Given this list of marker genes CDKN2A, RAPGEF6, SOS2, RFXANK, SDCBP, EPO, NOTCH1, GRAP, RABGEF1, GRB2, NRAS (NRAS proto-oncogene, GTPase), SYNGAP1, MAP2K1, DOK3, SPRY4, RASGRF1, PLD1, MRAS, SYDE1, ITPKB, RALGPS2, BRAP, RALA, FGF2, NGF, SHOC2, MMD2, DAB2IP, FGF10, TGFB2, RAPGEFL1 (Rap guanine nucleotide exchange factor like 1), KSR1, IQGAP3, RALGDS, KITLG (NCBI Gene Id 780897), CDKN1A, RAPGEF3, RASGRP2, GRAP2, RRAS2, RASA2, KRAS, RGL1 (NCBI Gene Id 23179), CRKL, RASSF1, SPRY2, RASGEF1C, DOK2, PARK7, MAPKAP1, STAMBP, DHCR24, NTN1, PPP2CB, PICALM, MAPKAPK5, RASA4B, RASGRP1, RB1, SYDE2, RAPGEF2, RIT2, SQSTM1, LAT, NTRK1, PLCE1, RAPGEF4, SPRY3, RALB, CDK2 (cyclin dependent kinase 2), FLCN, RASA4, TRIM67, RASAL1 (NCBI Gene Id 8437), RASGEF1A (NCBI Gene Id 221002, RasGEF domain family member 1A), USP8, RALGPS1, RGL2, USP50, DOK1, TP53, RASA3, RIT1, RAPGEF1, IGF1, GNB1, SHTN1, CCNA2, ERAS (NCBI Gene Id 3266), SOS1, RASAL3, ADRA2A, RRAS, RGL3, FOXM1, EPHB2, PLK2, G3BP1, NF1, RASGRP3, MFN2, STK19, RASGEF1B, KSR2, RASGRF2, NUP62, CSF1, NOTCH2, RABL3, FBP1, RAPGEF5, RGL4, SPRY1, RASGRP4 (RAS guanyl releasing protein 4), HRAS, LZTR1, here is a description of the gene set: species: Homo sapiens Human Gene Set: GOBP_RAS_PROTEIN_SIGNAL_TRANSDUCTION An intracellular signaling cassette in which a small monomeric GTPase of the Ras subfamily relays a signal.